Given this list of marker genes Ly6a, Pacsin2, Tspo, Pnp, Spint1, Hadhb, H2-T23, Bcl2a1b, Ifi27l2a, Clec4n, Ifitm2, Glrx, Lims1, Lap3, Ms4a7, Ndufc2, Gsap (NCBI Gene Id 212167), Psmd4, Cyp4f18, Tmpo, Ube2s, Sell, B2m, Il18bp, Psmc5, Lgals3bp, Slfn2, Ptpn1, Slc29a3, Tgfbi, Aif1, Ms4a4c, H2-Q7, Man2a1, Eif2ak2, Scand1, Tmed7, Ly6c2, Hif1a, Tapbpl, Ifitm3, Fabp5, Tor1a, Cstb, Prxl2b (peroxiredoxin like 2B), Tmem14c, Pgk1, Sp110, Ms4a6b, Ube2a, Cxcl9, Elob, Srsf2, Mitd1, Plac8, Cebpb, Ly6i, Lgmn, Il1rn, Pdk3, Vcam1, Zbp1, Pirb, Ms4a6c, Ly6e, Klra2, Serinc3, Psma7, Zfand3, Ppt2, Efhd2, H2-K1, Epsti1, Nfu1, Atp6v0b, Hck, Marcksl1, Scimp, Irf7, Psmb9, Dusp6, Stard3, Lyn, Isg15, here is a description of the gene set: Cytokines mediate cell-cell communication in the immune system and represent important therapeutic targets. A myriad of studies have highlighted their central role in immune function, yet we lack a global view of the cellular responses of each immune cell type to each cytokine. To address this gap, the authors created the Immune Dictionary, a compendium of single-cell transcriptomic profiles of more than 17 immune cell types in response to each of 86 cytokines (>1,400 cytokine-cell type combinations) in mouse lymph nodes in vivo. A cytokine-centric view of the dictionary revealed that most cytokines induce highly cell-type-specific responses. For example, the inflammatory cytokine interleukin-1β induces distinct gene programmes in almost every cell type. A cell-type-centric view of the dictionary identified more than 66 cytokine-driven cellular polarization states across immune cell types, including previously uncharacterized states such as an interleukin-18-induced polyfunctional natural killer cell state. Mouse Gene Set: CUI_CDC2_IL27_RESPONSE_UP from publication Cui A, Huang T, Li S, Ma A, Pérez JL, Sander C, Keskin DB, Wu CJ, Fraenkel E, Hacohen N (PMID 38057668) species: Mus musculus Genes positively differentially expressed in cell type: cDC2 (conventional dendritic cell type 2) upon treatment with cytokine: IL-27 in mouse lymph nodes in vivo.